The following is a description of a gene set: species: Mus musculus An inflammatory response to an exogenous environmental antigen or an endogenous antigen initiated by the adaptive immune system. Mouse Gene Set: GOBP_HYPERSENSITIVITY, and this is the list of marker genes: Gata3, Fcer1a, Fcer1g, Fcgr4, Ephb6, Zp3, C3, Ighg2b, Fcgr1, Ighe, Fcgr2b, H2-T23, Ext1, Spn (sialophorin), Btk, Il20rb, Fut7, Ighg1, Fcgr3, Ccr7